Given this list of marker genes APPL2, HMGB1, FCN2, RAB11FIP2, TBK1, LETMD1, OAS1, LY96, MIR140, NFKBIA (NCBI Gene Id 4792), TRAF6, COLEC11, RIPK2, TIRAP, IRAK4, SYK, IRAK1, MIR200B, LTF, NAGLU, TRIM32, MIR708, SCIMP, MIR20A, CHUK, TICAM2, TLR4, TLR5, APPL1, LILRA2, PTPN22, TMEM126A, MYD88, TNFAIP3, MIR200C, ACOD1, PIK3R1, TRIL, TICAM1, RAB7B, NMI, FCN3, TAX1BP1, NR1H3, TREM2, ECSIT, RELA, TNIP3, MIR210, MFHAS1, LGALS9, IRAK2, TLR2, DAB2IP, TLR6, FLOT1, CYBA, BPIFB1, MIR146A, NINJ1, LYN, TRAF3, IFI35, NR1D1, F2RL1, MAP3K7, MIR149, MBL2, CLEC7A, LBP, FFAR2, S100A14 (S100 calcium binding protein A14), SQSTM1, IRF3, WDFY1, TLR1, PRKCE, PELI1, TNIP2, PIK3AP1, FCN1, CD14, ZNRF1 (NCBI Gene Id 84937), COLEC10, PJA2, here is a description of the gene set: The series of molecular signals initiated by a ligand binding to a cell surface pattern recognition receptor (PRR). PRRs bind pathogen-associated molecular pattern (PAMPs), structures conserved among microbial species. studied in species Homo sapiens Human Gene Set: GOBP_CELL_SURFACE_PATTERN_RECOGNITION_RECEPTOR_SIGNALING_PATHWAY